The following is a description of a gene set: species: Homo sapiens Human Gene Set: DESCARTES_MAIN_FETAL_CILIATED_EPITHELIAL_CELLS from publication Cao J, O'Day DR, Pliner HA, Kingsley PD, Deng M, Daza RM, Zager MA, Aldinger KA, Blecher-Gonen R, Zhang F, Spielmann M, Palis J, Doherty D, Steemers FJ, Glass IA, Trapnell C, Shendure J (PMID 33184181) Marker genes curated from the annotated cluster as represented in the Descartes Human Gene Expression During Development database. The gene expression program underlying the specification of human cell types is of fundamental interest. The study authors generated human cell atlases of gene expression and chromatin accessibility in fetal tissues. For gene expression, the study authors applied three-level combinatorial indexing to >110 samples representing 15 organs, ultimately profiling ~4 million single cells. The study authors leveraged the literature and other atlases to identify and annotate hundreds of cell types and subtypes, both within and across tissues. Our analyses focused on organ-specific specializations of broadly distributed cell types (such as blood, endothelial, and epithelial), sites of fetal erythropoiesis (which notably included the adrenal gland), and integration with mouse developmental atlases (such as conserved specification of blood cells). These data represent a rich resource for the exploration of in vivo human gene expression in diverse tissues and cell types., and this is the list of marker genes: SOX30, DUSP19 (dual specificity phosphatase 19), TBC1D8, MIPEP, COPRS, CC2D2A, ADGB, ZNF599, LIAT1, BBOF1, RFX3, SMIM6, CEP83, IFT172, ANKRD44-AS1, AK8 (adenylate kinase 8), INTS10, IQCA1, CLUAP1, ACBD3-AS1, TTC21A, ROPN1L, EFCAB6, CDHR18P, XPNPEP3, DYNLT5, CFAP90, FAM81B, RIBC1, NEK5, ANKEF1, ANKRD54, PIERCE2, PRR29, WDR54, DYDC1, CIMAP3, CCDC157, DHX40, RABL2A, SPATA6L, CTXN1, ODAD1, CFAP251 (cilia and flagella associated protein 251, NCBI Gene Id 144406), CFAP61, TTLL9, CCDC78, RNF6, C20orf96, NEK2-DT, TPRG1L, TEKT4, EFCAB12, DYNC2I1, BBS12, MOK, ENSG00000237429, FAM181A-AS1, CFAP46, CFAP100, WDR19, IFT70B, LRRC10B, DNAAF6, DNAI2, ERICH2-DT, DYNLT1, DNAH2 (dynein axonemal heavy chain 2), MAP9, AK7, CFAP20, TTC12, HSP90AA1 (NCBI Gene Id 89272), CABCOCO1, SPACA9, HIPK1, COQ7-DT, RPL21P54 (ribosomal protein L21 pseudogene 54), GAS2L2, CCDC39-AS1, VRK3, LINC02605, OR7E36P, P4HTM, PIERCE1, CIMIP6, ENSG00000269091, CFAP92, DNAI7, AHSA1, MAPK15, DYNLL1, LINC00475, CFAP95 (cilia and flagella associated protein 95), CCDC40, DNAL4, HIPK3, KNDC1, NWD1, LINC02057, MEIG1, CCDC81, DNAI4, MS4A8, CFAP107, SANBR, TMEM190, MORN5, FHAD1, ARHGAP39, LINC01435, LINC01707, CFAP221, ZNF132, LINC01765, CIMIP2C, TMEM231P1, CENPBD2P, SYS1, DERL3, CIMAP1B, NRAD1, DLG5-AS1, HCG14, CHST9, CSRP3-AS1, LRGUK, TGM3, ZMYND10-AS1, CFAP44-AS1 (CFAP44 antisense RNA 1), CRACDL, PAPOLA-DT, DYNLT4, KIAA0825, EMC3, C16orf46, THBS3-AS1, LRRC37A5P, IFT52, TARS1-DT, RPGR, AK9, KLF2-DT, RSPH4A, HOATZ (HOATZ cilia and flagella associated protein), LDLRAD1, C6orf118, RSPH9, SPAG8, FAM229B, GLB1L, DNAH10, FBXO36, SPEF2, ANKRD66, CFAP45, TUBB4B, APOBEC4, LEKR1 (NCBI Gene Id 389170), MORN1, DNAH5, WDR49, ERICH6-AS1, VSIG8, RNA5SP473, ALDH3B1 (NCBI Gene Id 221), CDHR4, LINC01671, CIBAR2, CIMIP1, CSPP1, IFT81, CFAP276, UMODL1-AS1, PRDX5, ASB14, LINC01392, MARCHF10, DZIP1L, DNAH1, HMGB1P16, MAPRE3, RSPH10B2, TMC5, ZNF391, LCA5, LCA5L, CCNO-DT, LRRC74B, NPHP1, LINC02231, NAT14, DNAAF4, CCDC146, SERTAD4-AS1, CATIP, SLC44A4, DNAH11, ITGB8-AS1, BCYRN1, FHIP1A-DT, GIHCG, CFAP47 (cilia and flagella associated protein 47), TMEM232, KCNE1, ARMH1, C21orf58, CCDC74A, IFT43, DPAGT1, MDH1B, STMND1, MIPEPP3, DNAH12, CRAT37, KIAA0753, CFAP206, CASC2, CFAP53, RWDD3-DT, ENO4, HNRNPF, IQCG, CFAP65, ENSG00000236495, DTHD1, SPATA4, CFAP70, PCM1, CFAP141, BBS5 (Bardet-Biedl syndrome 5), LRRC27, TTC34, TREM1, CIB1, CEP290, FBXO15, DYNC2I2, RSPH14, DNAAF1, TTC21B, LINC02031, FAM174A, TMEM231, CES1, TMEM212, MCAT, SAXO4, TMEM218, TTC16, RNF32, CDH13-AS2, LNCTAM34A, SRGAP3-AS2, SYNPR-AS1, DPCD, FSIP1, ENSG00000181123, LINC00589, PPP1R42, ODF2L, MNS1, TP73, IFT122, TM4SF19-DYNLT2B, C10orf95, FAM47E, LKAAEAR1, ZNHIT2, SPATS1, CCDC13, STPG1, EPPIN (epididymal peptidase inhibitor), ODAD4, DLEC1, NEK4, LRRC51, RSPH1, DALRD3, RIIAD1, GET1, GON7, FUZ, CCNA1, CCDC65, TMEM270, EEF1B2P4, SPA17, MTRR, ANKUB1, CFAP418-AS1, ARHGEF38, BTG4, TEKT1, DNALI1, CCDC103, ZNF475, NAT1, RNF157-AS1, SRI, LRRC18, PLEKHG7, RPGRIP1L, CDC20B, IFT57 (intraflagellar transport 57), SGMS2, LINC02345, AGR3, CCDC74B, CATSPERD, CIMIP2A, ZNF594-DT, EEF1B2P5, PPP4R4, SPATA17, CFAP43, CFAP91, IQANK1, C6orf52, CDNF, DRC12, SNRPF-DT, ENSG00000228944, RSPH3, ANKMY1, CFAP58, DOC2A, C1orf141, CBY1, NEK11, CFAP298, CFAP126, C9orf43, VCF2, ZNF19, GPR162 (G protein-coupled receptor 162), DEUP1, RN7SKP96, ENSG00000238185, IFT70A, HSPBP1, AKAP14, WDR93, TEX9, DNAAF3, UGT2B17, WDR41, LINC03086, ULK4, DNAJB13, CDHR3, ANKRD42, TTC29, SAPCD1-AS1, CFAP74, EFHC1, METTL27, CAPSL, TRAF3IP1, ZDHHC1 (NCBI Gene Id 748), VWA3A, CFAP119, IFT74, FAM227A, CHRNA9, ZNF584, TSPAN19, SAXO2, C11orf97, SPAG6, DNAH9, CFAP44, SPAG16 (sperm associated antigen 16), CCNO, RABL2B, URAHP, ARMH2, WRAP53, AKAP9, PRSS54, KATNIP, MINDY4, SAMD15, LRRC71, VWA3B, C7orf57, ZNF295-AS1, ZNF487, C22orf15 (NCBI Gene Id 150248), LNC-LBCS, TCTN1, RGS22, DCDC2B, C10orf67, IFT140, DNAI3, RB1CC1, TCP11, KNCN (NCBI Gene Id 148930), UNC119B, LINC01708, DPY30, KRT42P, ABCA13, LRP2BP (NCBI Gene Id 55805), LINC02166, DYNC2H1, OGFR-AS1, IK, NSUN7, GJB7, CFAP77, RB1-DT, ZNF474, EP300-AS1, ABITRAM, C5orf15, NUDT7, TTLL10, GALNS, ZNF20, LINC03053, EFCAB2, ZNF396, MROH9, CCDC30, STOX1, LRRC56, GRIN3B, WDR86-AS1, DNAH3, FRMPD2, GOLPH3-DT, GEMIN8, HAGHL, LRRIQ1, USP2-AS1, FOXJ1, SPATA33, IQCH, PITPNM1, TEX26, NUDC, MYCBP, RPL32P3, CIMIP5, CCDC160, DYDC2, SLC9C2, CFAP263, CCDC138, CFAP184, PRH2, JHY, ZSCAN18, SPAG1, EFCAB10, OMG (NCBI Gene Id 4974), PRR18, CFAP52, C1orf87, B9D1, CFAP300, TSPAN1, LMNTD1, TMEM107, UBXN10, ENSG00000234022, DCDC1, ZDHHC11, UFC1, ARMC3, KIF23-AS1, FAM86FP, CEP170P1, LINC01908, DENND6B, PCSK4 (NCBI Gene Id 54760), TROAP-AS1, HMGN3, CROCC, SCGB3A2, CFAP73, LINC01571, SMC2-DT, TEX56P, CCDC190, TEKT3, ENSG00000263011, CFAP299, KCNRG, MGAT4D, CENPS, RSPH10B, RAB36, PRSS12 (NCBI Gene Id 8492), RPP38-DT, CFAP144, CAPS2, DAW1, KIAA2012 (KIAA2012), P2RX6P, CAPS, MIR7515HG, DYNLT2B (NCBI Gene Id 255758), NHLRC4, C5orf46, DZANK1, CYB5D1, RPS8P5, FABP6-AS1, CROCC2, EFHB, CNGA4, CCDC191, TMEM67, SPATA18, NME9 (NCBI Gene Id 347736), ECT2L, HYDIN, SLFN13, CFAP54, UBXN11, B9D2, PACRGL, WDR35, C1QTNF8, CRISP2, RIBC2, STK33, C19orf44, ZBBX, OSBPL6, LRRC9, CLXN, DNAAF11, ADPRS, CCDC89, CFAP210, ODAD3, TTLL13, WDR38, FBXL13, COQ4, DUSP18, ARMC2, CLBA1, ZNF204P, CCP110, BRD3OS, ZNF214, PACRG, SPEF1, RNU4-46P, SPMIP6, CCDC33, IQCE, DRC1, ENSG00000258752, WFDC6, CNTN4-AS1, DNAI1 (dynein axonemal intermediate chain 1), KIF19, LINC01722, CFAP36, DNAH6, NME5, CFAP20DC, SPAG17, SMPD2, AHI1-DT, ODAD2, MAP3K19, CCDC17, ZNF473CR, ERICH3-AS1, LRWD1, LMLN, KIF27, LMNTD2, DNAAF10, ELL3, FAM216B, MRPS31, TOGARAM1, RAD17P1, SMIM34, IFT88, CLHC1, STOML3, DYNLRB2-AS1, LRRC43, LINC01970, GOLGA2P5, KCNH3, FNDC11, IQCD, LRRC46, TOGARAM2, ENKUR, MKS1, MORN3, FANK1 (NCBI Gene Id 92565), CFAP69, NRAV, LRRC23, NEK10, DNAAF2, SNTN, DNAJA4, DNAAF8, TUBA4B, VNN3P, TCTN2, LINC02958, LRRC34, OR7E47P, LINC02265, DMKN, TNFAIP8L1, TTC23L, CCDC181, CLDN16, ANKRD45, CETN2, LINC02300, LINC01927, CFAP157, DRC7, CCDC178, PZP, TMEM68, KLHDC9, CD164L2, CCDC180, FAM151B-DT, FABP6, MORN2, BBS4, CEP126, CDS1, TTLL6, HHLA2, STAM2, ENSG00000226484, POLR2I, IFT22, LPO, PACRG-AS3, PSENEN, ZNF688, CCDC170, NRG4 (NCBI Gene Id 145957), TTC41P, TSGA10, CFAP96, KIF9 (NCBI Gene Id 64147), DNAH7, C7orf78, LRRC73, ERGIC3, ERICH3 (glutamate rich 3), OSCP1, TMEM254, DNAL1, RFX2, RUVBL2, FBXW9, TPPP3, PPP1R36, DRC3, DYNLRB2, IQUB, ZMYND12, CCDC24, PTGES3, HSPH1, DZIP3 (NCBI Gene Id 9666), E2F3P2, TCTE1, IFT56, PPIL6, CFAP99, CAPS2-AS1 (CAPS2 antisense RNA 1), TEKT2